Given this list of marker genes F12, Pcsk1, Casp6, Casp4, Pisd, Hjv, Myrfl, Ctse, Dhh, Myrf, Fam111a, Pcsk2, Parp1, Pcsk9, Ihh, Capn2, Sprtn, Tmprss2, Fxn, Casp12, Shh, Afg3l2, Capn1, Oma1, Casp1, Pidd1, here is a description of the gene set: Processing which a protein carries out itself. This involves actions such as the autolytic removal of residues to generate the mature form of the protein. species: Mus musculus Mouse Gene Set: GOBP_PROTEIN_AUTOPROCESSING